Given this list of marker genes Zfp952, Rftn2, Gale, Prpf31, Nme5, Dppa4, Flad1, Gipr, Slc22a18, AW551984, Setd1b, Agmat, Nop10 (NOP10 ribonucleoprotein), Anxa3, Rttn, Tceal1, Npy4r, Wdr83os, Tmem63c, Prss35, Kctd20, Nicn1, Dennd2c, Tmem45a, Pclaf, Chrnb4, Slc37a4, Fbxo16, S100a1, Cnpy4, Aloxe3, Osbpl7, Apof, Zfp239, Smug1, Dync2li1, Synj2, Agpat4, Chac2, Cldn9 (NCBI Gene Id 56863), Lipa, Aadat, Odad1, Efhb, Prss8, Tmem125, Nap1l2, Gngt2, Ghdc, Cxcl1, Fbxw7, Crocc, Zfp871, Sv2a, Ift56, Slc4a10, Atp6v1g2, Krt17, Tmem106a, Zp3, Pou5f1, Rnf125, Mtcl3, Drc3, BC025920, Ppp1r42, Fbp2, Ip6k2, Dcaf4, Nfe2, Gprin3 (NCBI Gene Id 77535), Abi3, Oas1c, Nudt22, Gstp3, D630039A03Rik, Scn9a, Rcor2, Upb1, 2310030G06Rik, Cripto, Tmem119, Cpsf4l, Itgb7, Cox6b2, Irgm1, Mrpl35, Lpar2, Pyroxd2, Ak1, Stat4, Phkg2, Nmral1, Zmynd8, Emp1, Serinc4, Kdm6b, Fis1, Spsb3, Pank1, Eola1, Zfp87, Tcn2, Asb15, Hoga1, Fundc1, Traf3ip2, Elmo1, Wfdc2, Ube2d2b, Hspa1l, Tnfaip6, Fam222b, Tbx6, Tpcn2, Sema3a, Gm1070, Slc11a1, Slc9b2, Tmem198b, Elmo3, Hras, Hydin, Sfxn3, Adamts4, Usp49, Zfp108, Pcyt1b, Gdf5, Gjb4, Rln1, Timp1, Grb7, Slc7a3, Gng2, Arhgap18, Plin2, Cdc42ep5, Rpl10, Armc3 (armadillo repeat containing 3), Ubash3a, Zc3hc1, Gstm4, Stc1, Zfp35, Tcl1, Ttc12, Wdr12, Rin2, Sytl4, Gpx2 (glutathione peroxidase 2), Mvp, Zfp82, Gdf3, Katnal2, Calcoco2, Asprv1, Lysmd1, Krt222, Mlph, Nccrp1, Mybpc2, Pcsk1, Tacr2, P2rx3, Gm1123, Zscan10, Prr11, Supt7l, Hapln3 (NCBI Gene Id 67666), Slc44a2, Mpv17, Tlr3, Ctso, Sh3bgrl, Aldh1l1, Clcn5, Zfp879, Prcp, Sspn (NCBI Gene Id 16651), Rad54l, Adhfe1, Cpq, Scml4, Gemin6, Oprm1, Idnk, Ctu1, Srgap3 (SLIT-ROBO Rho GTPase activating protein 3), Pabir2, Spred3, Lsg1, Tek, Alkbh8, BC048507, Trim16, Inhbe, Flrt1, Fam13a, Ndst1, Tomm40l, Ptges, Nme7, Mospd1, Mbnl2, Rdh12, Spmip8, Kcnd1, Frg2f1, Zfp740, Plat, Zfp418, BC016579, Nol8, Erich6 (glutamate rich 6), Pla2g10, Timm21, Trap1a, Egfl6, Lin52, Gypa, Car9, Tceal8, Pbld1, P2rx7, Gstt1, Lama2, Hesx1, Tmem184a, S100a13, Cfap52, Zfp941, Fastkd1, Ehhadh, Lrrc34, Fn3k, Tfpi, Celf3, Adam18, Plet1, Zc3h12d, Fam186a, Zfp759, Oplah, Gpx8, Plin3, Chrna9 (NCBI Gene Id 69992), Syt3, Kctd14, Bmerb1, Rasgrp4, Rab19, Tfpt, Lifr, Crispld1, Gpr143, Hnf1a, Ly96, Sacs, Pglyrp1, Slc44a4, Zfp599, Igsf23, Asb7, Trpa1, Adprhl1, Pramel12, Iftap, Zfp109, Adipor2, Atg4a, Irgm2, Serping1, H2-DMa, Pcbd1, Def6, Zfp953, Axl, Mst1, Cstpp1 (centriolar satellite-associated tubulin polyglutamylase complex regulator 1), Cyp2j9, Dynlt4, Tmem141, Nrsn2, Scarf1, Atosa, Ccdc28b, Wdr38, Zkscan5, Amh, Tulp2, Flrt3, Zfp811 (zinc finger protein 811), Tmem242, Ehbp1, Arhgef15, Riok2, Polr2k, Trpv2, Tmem67, Rdh11, Akr1b10, Tkfc, Inpp5j, Exoc4, Arhgef9, Trappc13, Apool, Mt3, Psd4, 4833420G17Rik, Rin1, Rbbp9, Mdh1b, Cldn14, Pycard, Calhm5, Cfap91, Pycr1, Ints9, Nr5a2, Dnajc4, Tlr2, Glra3, Ccdc68, Cryzl2, Fkbp10, Nudt13, Trmt10b, Akr1e1, Thbs3, Foxs1, Cyyr1, Sh3bgr, Nxpe4, Dynlrb2, Tppp3, Trim2, D6Wsu163e, Irag2, Sphkap, Zfp874a, Meak7, Cpt1c, Zfp27 (NCBI Gene Id 22689), Zfp763, Inha, Chm, Tbc1d22b, Mmachc, Pold4, Abhd14b, Fam3a, Mfng, Add3, Rai14, Dclre1a, Cpt1b, Fmr1nb, Brsk1, Syt5 (synaptotagmin V), Clic1, Spp1, Smarcal1, Pter, Trim10, Ppp2r3c, Stpg1, Inhbc, Hdgfl1, Arhgap30, Acsbg3, Sulf1, Mterf2, Ooep, Qprt, Zik1, Col1a1, Lamb2 (NCBI Gene Id 270417), Lin28b, Fut1 (fucosyltransferase 1), Gstm1, Zfp958, Ctns, Cald1, Fkbp14, Dock9, Ripor1, Rbp7, Ddx60, Dglucy, Cul4b, Lat, Capn1, Cxcl2, Syt1, Gimap9, Blzf1, G0s2, Cldnd2, A2m, Nobox, Armh4, Slc17a9, Ly6g6e, Ly6g6d, Fam169b, Slc9b1, Tgfb1i1, Gcdh, Nectin4, Stoml1, Cyb5r2, Rcn3, Pir, Ank3, Tcaf1, Lpar6, Zfp595, Klhl5, Gask1b, Etfbkmt, Traf1, Hmmr, Zfp677, Krt72, Nsun6, Etv1, Entrep3, Fndc11, Mamdc2, C1qtnf5, Bbs1, Hfe, Wbp1l, Zfp112, Klc3, Slc38a7, Lrrn4cl, Vps41, Sumf2, Zfp940, Plekhg1, Wdcp, Lima1, Arhgap8, Cwf19l2, Dnajc12, Scml2, Dnali1, Klc4, Apobec3, Jade1, Fundc2, Zfp788, Dok2, Abcc6, Spaca9, Tpp1, Fastkd2, Txlnb, Rpl19, Dclre1c, Ttc23, 4933428G20Rik, Grik5, Tvp23a, Crygn (crystallin, gamma N), Zfp317, Prrc2a, Casq1, Mall, Pbx1, Sipa1, Rp2 (NCBI Gene Id 19889), Trim29, S1pr4, Ccdc93, AI429214, Prim1, Mpst, Zfp646, Rbm41, Scn1a, Lrp1, Actn3, Echdc3, Col4a5, Dppa2, Ctnnd1, Pak1 (NCBI Gene Id 18482), Zfp54, Ccdc141, Csrnp3, Nrn1l, Atp5mc1, Slc35g3, Prss42, Slc12a6, Trim46, Zfp454, Tal2, Cd99l2, Pbxip1, Tmem69, Akap6, Cdh15, Pm20d1, Zfp42, Xkr6, Bivm, Zfp395, Cda, Pus3, Gjb3, Dlg4, Decr2, Entpd3, Upk3b, Dppa3, Dusp19, Gab3, Mthfr, Hspb8, Gosr1 (golgi SNAP receptor complex member 1), Lysmd4, Sap30bp, Ptprcap, Lrrc74b (NCBI Gene Id 74685), Morc2b, Pml, Pgam2, Phc1, Serpine1, Liph, Fam111a, Aass, Mrgpre, Fbxo15, Ank2, Pramel13 (NCBI Gene Id 97182), Il23a, Faim2, Dnah2, Entpd1, Rab13, Zfp13, Tctn2, Lars1, Cd247, Grn, Nrxn1, Trappc14, Mgst1, Dennd2b, Hspb6, Trak1, Gria3, Slc2a10, Snx31, Cutal, A430033K04Rik, Zfp52, Gng11, Patl2, Oas1b, Tbkbp1, Tlk2, Ccdc65, Cacng1, Plekhg5, Padi4, Wdr95, Zfp260, Col5a3, Washc3, 2410137M14Rik, Cd3e, Ryr1, Glb1l2, Scnm1, Hdac6, Ypel4, Abcd2, Nfkbid, Zfp870, Nckap5, Sat2 (spermidine/spermine N1-acetyl transferase 2), Resp18, Aldoc, Zswim9, 2810408A11Rik, Srrm3, Ldhd, Eid3, Camk1, Ccdc77, Cfc1, Tor1aip2, Col7a1, Fkbp7, Zcchc13, Psg16, Neil1 (nei endonuclease VIII-like 1 (E. coli)), Osgepl1, Dynlt3, Lrrc2, Acsl5, Fgr, Spn, Itm2a, Dnai3, Vps50, Zc4h2, C1qtnf1 (C1q and tumor necrosis factor related protein 1), Tmem82, Krt71, Arhgap45, Akap7, Galm, Ttll9, Pak6, Zfp40, Zfp276, Zfp750, Tmc4, Adm2, Syn3, Enpp3, Rassf6 (NCBI Gene Id 73246), Golph3l, Hmg20a, Rbm4, Mtmr11, Spef1, Megf10, Trim54, Il15, Sh3tc2, Gid8 (GID complex subunit 8), Acy1, Recql5, Nqo1, Tsnaxip1, Thrsp, Calhm2, Serpini1, Wdr24, Tjp3, Tnk1, Zfyve26, Dapp1, Ftsj1, Foxh1, Mettl15, Cyct, Unc5cl, Frrs1, Pla2g2c, Upk2, Jmjd8, Zfp84, Tmem14a, Prss39, Cmklr2, H1f6, Zfp182, Ccdc39, Dpp7, Ech1, Pla2g12b, Miox, Fitm1, Tspoap1, Elf3, Sparc, Atxn7l1, Bcl2l2, Cyp2j13, Gtf2h4, Rnf186, Tmem139, Cend1, Hyal1, Dnase1l1, Slc12a3, Cmklr1, Rhbdl2, Rfx5, Bak1, Actr6, Npffr2, Bst1, Gmppa, Rbms2, Efcab12, Kcna4, Ifitm3, Mical1, Tcim, Dgkb, Lmod1, Tmem154, Lhcgr, Aym1, Gm128, Zfp93, Pkp3, Plpp7, Pafah2, Pon3, Fancd2os, Aox1, Nosip, AW209491, Mcts1, Trim63, Gap43, Tut1, Gbp6, Cnksr1, B230217C12Rik, Zmat5, Rad51b, Smim26, Or2c1, Gsta4, Ccdc160, Gdf15, Atcay (NCBI Gene Id 208757), Tmem256, 4930550C14Rik, Pierce1, Igbp1, Clec2d, Zranb3, Ppp2r5c, Lgals12, Abca8b (NCBI Gene Id 27404), Zbtb4, Fam83e, Cbln3, Mpi, Nhsl1, Nat14, Alpk3, Gdap1l1, Acp3, Car3, AI467606, Adal, Med24, Gjb5, Ifitm2, Fam149a, Trim6, Alg3, Bpgm, Chrng, E230025N22Rik, Slc25a41, Hsd17b11, Rnf208, Cd38, Cyp2d22, Itih5, Ifit2, here is a description of the gene set: Genes with intermediate-CpG-density (ICP) promoters bearing histone H3 K4 trimethylation mark (H3K4me3) in embryonic stem cells (ES). Mouse Gene Set: MIKKELSEN_ES_ICP_WITH_H3K4ME3 We report the application of single-molecule-based sequencing technology for high-throughput profiling of histone modifications in mammalian cells. By obtaining over four billion bases of sequence from chromatin immunoprecipitated DNA, we generated genome-wide chromatin-state maps of mouse embryonic stem cells, neural progenitor cells and embryonic fibroblasts. We find that lysine 4 and lysine 27 trimethylation effectively discriminates genes that are expressed, poised for expression, or stably repressed, and therefore reflect cell state and lineage potential. Lysine 36 trimethylation marks primary coding and non-coding transcripts, facilitating gene annotation. Trimethylation of lysine 9 and lysine 20 is detected at satellite, telomeric and active long-terminal repeats, and can spread into proximal unique sequences. Lysine 4 and lysine 9 trimethylation marks imprinting control regions. Finally, we show that chromatin state can be read in an allele-specific manner by using single nucleotide polymorphisms. This study provides a framework for the application of comprehensive chromatin profiling towards characterization of diverse mammalian cell populations. studied in species Mus musculus from publication Mikkelsen TS, Ku M, Jaffe DB, Issac B, Lieberman E, Giannoukos G, Alvarez P, Brockman W, Kim TK, Koche RP, Lee W, Mendenhall E, O'Donovan A, Presser A, Russ C, Xie X, Meissner A, Wernig M, Jaenisch R, Nusbaum C, Lander ES, Bernstein BE (PMID 17603471)